The following is a description of a gene set: studied in species Homo sapiens Either of the lipid bilayers that surround the nucleus and form the nuclear envelope; excludes the intermembrane space. Human Gene Set: GOCC_NUCLEAR_MEMBRANE, and this is the list of marker genes: PRNP, RB1CC1, NRM, SENP1, GAPDH (NCBI Gene Id 2597), SMAD3, ATP2A3, SUMO1, NAV3, DNAJC1, PTGS2, ADRA1B, CDH5, SH3BGRL2, NUP85, ZBED1, IL15RA, WDR3, KCNH1, NOS1AP, HABP4, NSMF, GCH1, DNAJB14, LBR (lamin B receptor), TMEM120A, HAX1, ENO1, CCNI, EGFR, RBMX2, TMEM176B, SUN3, DUSP2, CLCA2, QSOX2, NPAP1 (nuclear pore associated protein 1), SIRT1, DTL, NUP58, POM121, MYOF, LMNB1, DCTN5, CEP128, PAK5, TMEM201, TMEM147, MAD2L1BP, TNRC18, WDFY3, PRKG2 (NCBI Gene Id 5593), NUP133, FAM169A, MTDH, LMNA, TEX2, EMD, PHF8, BRIP1, EPC1, KASH5 (NCBI Gene Id 94029), TCHP, GTPBP4, MFSD10, RANGAP1, KPNA4, SMPD4 (sphingomyelin phosphodiesterase 4), IPO5 (NCBI Gene Id 3843), ALOX5, INTS5, LRRK2, TMEM38A, SPATA46, P2RX6, EPHA3, CMTM3, TMEM18, NPIPA1, DTX2, GUCA1B, RETSAT, TMPO, SORT1, CANX, RNF13, ATP5MF, CBX3, TMEM109, ZNF354C, TM7SF2, DUX4, PTGDS, ADRA1A (NCBI Gene Id 148), TMEM168, FZR1, NLRP10, IFI27, DNAJB12, STAU2 (staufen double-stranded RNA binding protein 2), LRPPRC, TBC1D20, BCL2L1, TMC8, VAPA, KPNA2, TOR1AIP1, SEPHS1, NUP205, ERBIN, DNAJB2, LYPLA1, PLCB1, DHCR7, NUP210, NDC1, CLIC1, MYORG, SENP2, CNEP1R1, PRICKLE2, PAK1, NUTF2 (NCBI Gene Id 10204), TOR1B, SYNE3, NUP98, CPTP (ceramide-1-phosphate transfer protein), ANKRD17 (ankyrin repeat domain 17), KIF5B, DPY19L2P2, DISP3, RIF1, RAP1GAP2, TTC12, HOXA7, LEMD2, POM121C, SPAG4, ITPRIP, LPIN1, SLC5A1, MAJIN, TERB2, MACO1, PCM1, BCL2L10, EI24, PHF11, OSBPL6, TMCO5A, NUDT9, GRK5, MX1, GNAQ, MYO6, CD38, SLC22A3, CLMN, PLRG1, AAAS, SHISA5, SYNE4, CTDNEP1, MATR3, GUCY2F, EDNRB, RAB29, IFT122, MINDY3, SMAD1, AHCTF1, INPP4A, FAM209A, KPNB1, WTAP, SIGMAR1, TMEM120B, DMPK, LTC4S, SUN5, RNF123, CDK4, PML, ITPR3, PUM2, TNKS, OSBPL8, EBP (NCBI Gene Id 139151), AKAP6, NUP50, NUP54, CCND2, NUCB2, TRIM27, TENT4A, POMZP3, TRAPPC2B, TRA2B, RNF6, NUP35, ERN1, SMOX, PIK3C2B, XPO1, NUP153, NUP42, CCND1, SCRN1, TPR, BCL2, PHF20, ARL6IP6, RTEL1, PDE4D, ITPR1, DYNC2I2, TERB1, KLHDC2, LMNB2, NRXN1, UTP18, MCM3AP, SNCA (synuclein alpha), ZMPSTE24, SUN2, PSEN2, NEMP2, CUEDC2, BOK, STX1A, ALOX5AP, NUP62, NR4A1, GTF3C3, NUP93, AKIRIN1, GATA6, THAP7, ZNF224, AQP1, KLK6, TXLNG, SYNE1, HPN, TMEM53 (transmembrane protein 53), ZC3HC1, MPL, GHRHR, TMC6, IFFO1, SCAI, TMEM97, CENPV, PSEN1, GLE1, TOR1AIP2, APEH, LEMD3, TMEM43, OSBPL7, ZBTB1, H2BW1, REPIN1, ABL1, HACD3, ATP11B, NOC4L, SULT1E1, AK9, SPAST, CPNE1, AEN, QRICH2, UNC50, ITGB4, INTS2, DHX37, MRGPRF, RANBP2, YEATS4, SUN1, RBM15, BROX, MRPS23, CREB3L4, GUCY2D, DNAJC2, FAM209B, PRICKLE1, SDCBP, SLC52A3, CEMIP, CEPT1, NLRP6, DPY19L2, HMGA1, SPIN1, NEMP1, OSBPL3, ATP1B4, SYNE2, AMBP, UGT2B28, NUP107, C9orf72, PAFAH1B1, TOR1A, BRAP, TMX4, SLC16A3, CASC3, MLX, SLC30A1, ZNF383, NUP155, ANXA4, MRPS14, ACKR2, TMEM38B, TAF3, SURF4, GCHFR, RRP12, PLPP6, INTS1